Given this list of marker genes GJB4, RAD1, ARL4A, ZNF805, RIT1, ABCA13, MAP3K2, TAF9B, ABCE1, AQP5, PHF20L1, ARHGAP42, ELOA2, NRP1, MYO3B, CAT, SVIP, PDIK1L, NOTCH2NLA, ATP4B, MTMR7, AGL, APPL1, MTCH2, MARK1, YOD1, GLB1 (galactosidase beta 1, NCBI Gene Id 2720), TRIM6-TRIM34, PACSIN2, DSG2, ANXA9, SCCPDH, TRIM34, CRISP1, SLC17A2, COL4A1, FERMT2, NT5C3A, CNTN1, PDE9A, DIPK2A, CALD1, MACROH2A1, SNX11, YWHAB, QSER1, IMPA1, SYNJ1, KPNA3, STK32A, ITGA9, NPL, TSPAN12, WAPL, PTPRG, KDM7A, MON2 (MON2 homolog, regulator of endosome-to-Golgi trafficking), PIK3C2A, ANKRD36C, CSF2RB, C12orf75, GRM6, GRIN1, LRCH1, NPEPL1, ADAT2, VWA2, KLF5, BICC1, SLC38A1 (NCBI Gene Id 81539), MEIOC, MIER3, DCAF12, SPEF2, SERINC5, ESRRG, LRP4, ANKRD29, TCAIM, FGFR2, ANKRD36B, ZSWIM6, PTCH1, PTPRE, TGS1, EPB41L4B, TMEM218, AAR2 (AAR2 splicing factor), TENM3, FBXW2, LIN7A, CDC42, here is a description of the gene set: from publication Chen Y, Wang X (PMID 31504780) studied in species Homo sapiens Human Gene Set: MIR5094 Genes predicted to be targets of miRBase v22 microRNA hsa-miR-5094 in miRDB v6.0 with MirTarget v4 prediction scores > 80 (high confidence targets).